The following is a description of a gene set: Changes in mouse liver mRNA profiles following intraperitoneal cytokine injection. Either interferon-gamma-/-, albumin-cre(-) Socs3(w/fl) mice, or albumin-cre(+) Socs3(-/fl) mice were injected with either phosphate-buffered saline, interferon-gamma, or interfeukin-6, and livers taken after 4h. Human Gene Set: GSE369_IFNG_KO_VS_WT_LIVER_DN Genes down-regulated in liver: IFNG knockout versus wildtype. from publication Croker BA, Krebs DL, Zhang JG, Wormald S, Willson TA, Stanley EG, Robb L, Greenhalgh CJ, Förster I, Clausen BE, Nicola NA, Metcalf D, Hilton DJ, Roberts AW, Alexander WS (PMID 12754505) species: Homo sapiens, and this is the list of marker genes: RPIA, TRMU, SMYD2, PPP1R8, MMACHC, KCNA3, MTM1, C1QBP, MRPL55, DPH6, TFPT, NDUFB5, MRPL11, CRCP, PNPO, PDSS2, HLA-DQA1, SNHG12, RSL24D1 (ribosomal L24 domain containing 1), PFDN4, NAF1, KBTBD8, UFM1, DYNLL2, CLUH, NOL8, AATF, MRPL47, MRPS15, AIMP2, MRPL18, PARD6B, GRN, PIGY, RUVBL1, IPO7, RAP1A, PPIB, PMPCA, DUS1L, NOP10, WDR89, TBL3, NR2C2AP, EPRS1, USP36, SNRPD1, LMO2, EMG1, G6PC3 (glucose-6-phosphatase catalytic subunit 3), SLC25A6, TIMM23, MRPL23, BCAS2, ATG2B, ARHGDIG, COQ5, EARS2, HSD17B12, SUCLG2, UBE2V1, ZDHHC13, NOP2, USP14, CARNMT1, MRPL20, TMEM160, ENDOG, GATC, ALPL, EMC6, ODC1, GTF2H4, TFB2M, EIF4E, SRSF6 (serine and arginine rich splicing factor 6), EIF4G1, YIF1B, DRG2, PECR, PSMC5, TIMM44, PTCD2, UTP14A, ELL2, SLC38A5, CARS1, C1D, FPGS, MECR, SYNDIG1L, TRMT10C, PDAP1, SNRPD3, CORO2A, HMBS, SOCS3, SND1, TMEM229B, ATP8B2, CCR7, PCP4, RPP25, NFX1, PCYT2, CDC25A, FARSA, SLC15A3, DNAJB11, GLRX5, USP16, PHB2, NIFK, C1orf122, BOP1, POLR1G, TXNL1, LRRC24, HDDC2, PSMA4, EIF4A1, PDXP, TP53RK, RPUSD2, MCTS1, CS, PRR5, PNPT1, RANBP9, HSPA5, SPART, TOMM40, WDR55, EIF6, ATP23, RRP36, DNAJC11, NDUFAF6, MARS1, GATB, MLLT6, EIF2S3, TMEM238, METTL26, TIMM13 (NCBI Gene Id 26518), KCTD5, HAUS2, U2AF1, SLC16A6, PPIF, ATP1A1, BTLA (NCBI Gene Id 151888), HDLBP, ABT1, FOXRED1, HSP90AB1, ABCD4, CACYBP, GEMIN5, CDR2 (cerebellar degeneration related protein 2), NME4, LNPK, FABP5, ORC3, TRNT1, DDX56, GARS1, GRPEL1, TRAPPC5, DERA, MIPEP, BPNT1, TMEM123, C8orf82, TMEM248, AKAP1, WDR18, WDR12, FAM185A, B3GNT5, CRHBP, G6PD, NPRL3, GOLM2, CSF2RB, CYB5B, ATF6B, CHCHD1, COA7, RPAP3, FKBP2, HELLS, FTSJ1, ATP6V1H, TSPAN3, ALG1 (ALG1 chitobiosyldiphosphodolichol beta-mannosyltransferase), TNFSF11, PDCD2L, CEBPZ, TUT1